Given this list of marker genes AFF4, TRAPPC11, GJA8, HACE1, RNH1, GJA5, here is a description of the gene set: studied in species Homo sapiens Human Gene Set: HP_EXOPHORIA A form of strabismus with one or both eyes deviated outward to a milder degree than with exotropia. Exophoria